Given this list of marker genes POLD2, BLM, LIG1, RPA3, RPA2, POT1, POLD3, RPA1, WRN, TERF2IP, TINF2, TERF2, TERF1, FEN1, POLD4, PCNA, POLD1, DNA2, ACD, here is a description of the gene set: Once polymerase switching from pol alpha to pol delta is complete the processive synthesis of a short run of DNA called an Okazaki fragment begins. DNA synthesis is discontinuous and as the extending Okazaki fragment reaches the RNA primer, this primer is folded into a single-stranded flap, which is removed by endonucleases. The process of extension is completed by the ligation of adjacent Okazaki fragments. Reactome Pathway: Processive synthesis on the C-strand of the telomere part of: Telomere C-strand (Lagging Strand) Synthesis species: Homo sapiens